Given this list of marker genes UBALD1, EPHX1, MFHAS1, SPTBN1, SLC66A1, CHST15, SCML4, TTC3, SOX4, RPS15A, DIP2B, ABL1, CRYBA2, BAP1, ATP1B1, TMEM106C, NEUROD2, TDRP, RRAS2, CCL7, FCER2, RABAC1, POR, UBR1, GTPBP1, STX1A, IL4R, IRF6, RASA2, USP36, CXXC5 (CXXC finger protein 5), DICER1, CAMKK1, UTRN, RFLNB, PCNX1, PMEPA1, PRDX6, ERAL1, YPEL3, IL7R, EPB41L4B, IQCC, CTDP1, APPL2, ERBB3, PIM2, SSTR1, SLTM, CRLF3, NEDD4L, MGA, CEP350, CCNL2 (cyclin L2), SPOCK2 (NCBI Gene Id 9806), LRIG1, DPH2, IL17RA, SMAD7, MSL1, KCNA3, PIK3CD, DDX60, MEPCE, RAMP3, CREBBP (NCBI Gene Id 1387), RBM39, CCR6, C19orf48P, IRF9, ABLIM1, GDF11 (growth differentiation factor 11), TRAPPC12, ESS2, ZNF276 (zinc finger protein 276), PHAF1, IL5RA, TUT1, TRPC4AP (NCBI Gene Id 26133), CTDSP2, RAB40C, TRAF6, FAM120B, CXCR5, CCDC91, RPS21, FRAT2, HS1BP3, DNAJC27, BACH2, CERK, ZNF764, LANCL1, FBXO21, SATB1, TEF, SGTB (small glutamine rich tetratricopeptide repeat co-chaperone beta), PDE2A, KLK8, PGAP6, GID4, SMAD1, SLC41A1, SIX5, CCDC117, JMY, PNPO, RNF7, RPTN, CLDN3, RAPGEF6, LDLRAD4, TCF7, EZH1, NKX2-3, IMP3, MYOCD, INS, CD79A, TSR2, HERC1, REG4, RARA, KDM4B, ELK4, ARRB1, RAB3IP, PLAUR, PPCS, RETREG1, CCR9, GSTM2, ITGA6, MAP2K7, FBXO32, MEN1, SLC12A7 (solute carrier family 12 member 7), PDE4B, WDR45, ITK (NCBI Gene Id 3702), AXIN2, ACVR1B, TSPAN1 (NCBI Gene Id 113345), TAF1C, TMEM42, TIMP2, IL6ST, FHIT, CIC, SERPINF1, RPS9, CAVIN1, IGFBP4, AAR2, AXIN1, SMAD4, RCCD1, MRM3, RREB1 (NCBI Gene Id 6239), RERE, ZNF467 (NCBI Gene Id 168544), RPL26, F2RL1, KCNJ1, CHKA, SMOC1, SFMBT2, MMP1, DNAJB2, TTF1, IKBKB, HUWE1, ESRRG, NGEF, ADRA2B, CBFA2T2, BLK, CRYAB (crystallin alpha B), MAP3K3, BICDL1, MT4, CCKBR, FBXO28, TANC1, CNR2, ZNF746, NPC2, NR2C1, ANKRD17, PPP2R2A, IL2RG (interleukin 2 receptor subunit gamma), CEP112, BCL2, CAMSAP1, NIN, IRS2, MAPK8IP1, SESN1, TTC28, here is a description of the gene set: species: Homo sapiens Pan-Hdac inhibitors (HDACi) are endowed with a potent anti-inflammatory activity, but the relative role of each of the eleven Hdac proteins sensitive to HDACi to the inflammatory gene expression program is unknown. Using an integrated genomic approach we found that Hdac3-deficient macrophages are unable to activate almost half of the inflammatory gene expression program when stimulated with lipopolysaccharide (LPS). A large part of the activation defect is due to loss of basal and LPS-inducible expression of IFNb, which in basal cells maintains Stat1 protein levels, and after stimulation acts in an autocrine/paracrine manner to promote a secondary wave of Stat1-dependent gene expression. We show that loss of Hdac3-mediated repression of nuclear receptors leads to hyperacetylation of thousands of genomic sites and associated gene derepression. The upregulation of the constitutively expressed prostaglandin endoperoxide synthase, Ptgs1 (Cox-1), has a causative role in the phenotype, since its chemical inhibition reverts the Ifnb activation defect. These data may have relevance for the use of selective Hdac inhibitors as anti-inflammatory agents. from publication Chen X, Barozzi I, Termanini A, Prosperini E, Recchiuti A, Dalli J, Mietton F, Matteoli G, Hiebert S, Natoli G (PMID 22802645) Genes down-regulated in macrophages with heterozygous knockout of HDAC3: untreated versus LPS. Human Gene Set: GSE33162_UNTREATED_VS_4H_LPS_STIM_HDAC3_HET_MACROPHAGE_DN